The following is a description of a gene set: Genes up-regulated in comparison of polysome bound (translated) mRNA versus total mRNA 16 h after LPS (TLR4 agonist) stimulation. Human Gene Set: GSE14000_TRANSLATED_RNA_VS_MRNA_16H_LPS_DC_UP from publication Ceppi M, Clavarino G, Gatti E, Schmidt EK, de Gassart A, Blankenship D, Ogola G, Banchereau J, Chaussabel D, Pierre P (PMID 19943945) studied in species Homo sapiens Dendritic cells (DCs) are the sentinels of the mammalian immune system and they undergo a complex maturation process mediated by activation upon pathogen detection. Recent studies described the analysis of activated DCs by transcriptional profiling, but translation regulation was never taken in account. Therefore, the nature of the mRNAs being translated at various stages of DC activation was determined with the help of translational profiling, which is the sucrose gradient fractionation of polysomal-bound mRNAs combined to microarrays analysis. Total and polysomal-bound mRNA populations were compared in immature (0h) and LPS-stimulated (4h and 16h) human monocyte-derived DCs with the help of Affymetrix microarrays. Biostatistical analysis indicated that 296 mRNA molecules are translationally regulated during DC-activation. The most abundant biological process among the regulated mRNAs was protein biosynthesis, indicating the existence of a negative feedback loop regulating translation. Interestingly, a cluster of 17 ribosomal proteins were part of the regulated mRNAs, indicating that translation may be fine-tuned by particular components of the translational machinery. Our observations highlight the importance of translation regulation during the immune response, and may favour the identification of novel gene clusters or protein networks relevant for immunity. Our study also provides information on the possible absence of correlation between gene expression and real protein production in DCs., and this is the list of marker genes: RIOX1, VRK1, FTO, RBMY2FP, PRG4, RYR3, CPA3, CRAMP1, WFDC12, DPY19L3, SLC38A4, ADAM18, UHRF1, LRRC8A, INTS8, CENPF, PHKA2, PKP2, AP1G1, DIAPH1-AS1, SSX2IP, WDR19, KRTAP8-1, SAMD11, KCNT2, TRIM64EP, TNK2-AS1, SERPINB13, SLC25A48-AS1, TGOLN2, NCSTN (nicastrin), ARHGEF18, TAS2R39, ATN1, LINC00852, WDR64, AKNA, ATP9B, MCHR2-AS1, RNF175, DNAJB12, NPHP3, PDHA1, ALDH5A1, PEX5, MRPS5, TMEM190, GLT8D2, TMEM247, F13B (coagulation factor XIII B chain), CIT, CTPS1, HOOK2, LGALS13, CSTPP1, EXOC3L1, RAG1, ANXA10, ETV1, PRSS35, TNKS, SVOPL, PCED1B, GPM6A, RFESD, ZNF471, PALD1, GMEB2, ZNF862, GK2, YAE1, OBP2A, USP36, GSTA4, GLIS1, FITM2, OR10A3, ASB16, ZNF135, ACADSB, INTS4P1, HOXA5, CHST14, LTV1, FOXJ2, S100A7, FLRT3, BMS1P1, CFAP20, ILDR2, FMNL3, YARS1, SGSM2, OR2B6, DPP10, LRRC15, ANXA2P1, ZWINT, MICAL3, CYP4F30P, FANCG, MIPEP, NIF3L1, IKBKG, CIMIP2A, LINC00174, SCGB1D1, MPPE1, SLC51A, CCDC169, RNLS, SEMA4F, RAVER2, SLC17A3, SLC26A11 (solute carrier family 26 member 11), NEO1, TBC1D22A, BAHCC1, CHST4, TP63, FGFRL1, RNF183, DNMBP, RAB8B, FLCN, GPR6, ARSL, HOXD11, CAMKV, CNTN2, TMEM232, ATF6B, ABCB8, PPP1R27, LINC02796, SDC1, SLC25A17, BICRA, ADAM32, ZBTB20, BANF2 (NCBI Gene Id 284779), CXorf58, FAM201A, LINC00880, GEMIN4, CHRNA2, TIMM23B, CACNG2, SLC41A3, ALDH6A1, BRD3OS, MPLKIP, FBXL12, RNF186 (NCBI Gene Id 54546), PARP2, IRAG1-AS1, DNAJA3, TTC13, UNKL, CASP9, DPCD, PSG4, SCRIB, HNRNPD, PDE10A, RTP5, OPRM1, SCLY, P2RY13, LRATD1, SLC8A3, EXO1, H2AP, SLC29A3, GDF9, MAGEC1, MRPS31, AIRIM, VPS52, DCP1B, DRC1, SPMIP9, ZNF891, LEMD1, ZNF830, CYP2B7P, CRELD2